Given this list of marker genes Akirin2, Setd4, Il6ra, Ptpn22, Havcr2, Lilrb4a, Tnfaip3 (tumor necrosis factor, alpha-induced protein 3), Tnf, Arhgef2, C1qtnf4, Rabgef1, F2rl1, Tlr3, Rela, Tlr9, Il17d, Grk2, Crhr2 (corticotropin releasing hormone receptor 2), Inava, Nod1, Btk, P2rx7, Ifih1, Il17ra, Tlr1, Il1rap, F2r (coagulation factor II thrombin receptor), Tlr4, Flt3, Card9, Nr1h4, Il19, Il33, Ptpn6, Gpr141, Pycard (PYD and CARD domain containing), Tslp, Lbp, Rigi, Trem2, C5ar2, App, Tyrobp, Chrna7, Il1b, Arid5a, Rab7b, Il36b, Mapkapk2, Mavs, Adcyap1, Tut4, Cd74, Arrb2, Mapk13, Nod2, Tnfsf4, Pten, Nlrx1, Myd88, Afap1l2, Twist1, Aqp4, Nmb, Met (NCBI Gene Id 194383), Defb25, Laptm5 (NCBI Gene Id 16792), Cd47, Plcg2, Gba1, Lgals9, Ptafr, Cd300ld, Slamf1 (NCBI Gene Id 27218), Spon2, Ghsr, Mbp, Selenos, Sphk2, Tgfb1, Nckap1l, Azi2, Syk, Hgf, Tnfsf9, Il36a, Il17rc, Bpi, Ghrl, Lilra5, Il6, Prg4, Syt11, Wdr83, Il17a, Unc93b1, Il1rl2, Tlr6 (NCBI Gene Id 21899), Lep, Psen2, Ucn, Foxp3, Tmem106a, Xbp1, Ccn1, Fcer1g, Selenok, Hspd1, Il18, Zc3h12a, Pou2af1, Cd200r1, Csk, Zbtb20, C1qtnf3, Traf6, Stat3, Nos2, Aif1, Arrb1, Tlr8, Nlrc3, Ticam2, Scimp, Zg16, Ereg, Nmbr, Wnt5a, Ager, Tirap, Inpp5d, Dhx9, Tnfsf18, Ncl, Ripk2, Capn2, Trim55, Ash1l, Bsg, Cyba, Pou2f2, Cd24a, Trim30a, Cd36, Tnfrsf1a, Il36rn, Trpv4, Vegfd, Irak3, Bank1, Isl1, Il27ra, Hmgb1, Nlrp10, Elf4, Cebpb, Hyal2, Clec7a, Lilrb4b, Nlrp12, Tlr2, Il10, Tlr7, Il18rap, Ticam1, Muc16, Gas6, Il17f (NCBI Gene Id 96930), Il1a, Adora2b, Sirpa, Socs5, Foxj1, Klf2, Il36g, Il16, Tbc1d23, Ifng, Ccr5, Cd84, Lpl, Cd200, here is a description of the gene set: The appearance of interleukin-6 due to biosynthesis or secretion following a cellular stimulus, resulting in an increase in its intracellular or extracellular levels. studied in species Mus musculus Mouse Gene Set: GOBP_INTERLEUKIN_6_PRODUCTION